Given this list of marker genes MIEF2, C2CD5, TCAF1, CDK5R1, ERBB2, MTCL1, PAK1, MYO1C, AKT2, ITGAM, CIB1, ANK3, KCNB1, PDZK1, CDK5, SLC51B, ITGB1BP1, TCAF2, HRAS, HPCA, ITGB2, STOM, CHP1, CEMIP, MIEF1, FYN, PRNP, here is a description of the gene set: Any process that increases the frequency, rate or extent of the process of directing proteins towards a membrane, usually using signals contained within the protein. Human Gene Set: GOBP_POSITIVE_REGULATION_OF_PROTEIN_TARGETING_TO_MEMBRANE studied in species Homo sapiens